Given this list of marker genes Or6x1, Gm3953, Slc35f2, BC049987, Mir34c, Mir6244, Or8g21, Or8ab2-ps1, Arhgap20, Btf3-ps15, Fxyd2, Cd3e, Gm7293, Gm35835, A730065G17Rik, Or8ac1-ps1, Jaml, Gm8863, Olfr932-ps1, Treh, Gm24166, Or8c16, 1700110K17Rik, Bcl9l (NCBI Gene Id 80288), Zbtb16, Hyou1, Or8b1c, Clmp, Or8g52, Or10d5, Nectin1 (NCBI Gene Id 58236), Gm26249, Gm17540, Gm16322, Abcg4, Cbl, Mcam, 2900052N01Rik, Sdhd, Or10n1, Or8b1b, Atm, Or8c20, AI593442, Or10d1, Gm6981, Htr3b, 2610028D06Rik, Il18, Gm25562, 9430081H08Rik, Or8g50, Or8b57 (NCBI Gene Id 258824), Or8b43, Rnf26, 4931429L15Rik, Cyp19a1, Upk2, Or8g30, Or8b54, Gm16096, Scn3b, Apoa1, Or8g25-ps1, Gldn, Or8g26, Gm35371, Gm23271, Nkapd1, Gm5055, Gm9830, Or8b41, Gm48293, Gm24646, Atp5mg, Gm19709, Or8g27, Acat1, Oaf, Pou2f3, Apoc3, Cfap68, Ift46, Zpr1, Mir7086, Arhgef12, Or8g31-ps1, Tnfaip8l3, Ccdc153, Slc37a4, 4833428L15Rik, Exph5 (NCBI Gene Id 330943), Cul5, Gm4042, Plet1os, Lncbate3, Or8g53, Gm31614, Or8c9, Or8d4, Vps11, Gm40518, Usp28, Gm29909, 4933407I05Rik, Btg4, Or8d22-ps1, Or8b1, D630033O11Rik, Nnmt, Cxcr5, Gm39329, Or8g54 (olfactory receptor family 8 subfamily G member 54), Tbcel, Or8g2b, Mir7085, Or8g18, E230034D01Rik, Or8c15, Gldnos, Or8d1b, Skic8, Or8b55, Or8b48, Tmem25, Or8g17, Or8c14-ps1, Pou2af3, Gm4894, Gm1715, Or8c17, 1700063D05Rik, Dixdc1, Gramd1b, Gm7286, Gm47475, Hspa8, Gm16124, Or8g28, Or10s1, Gm22540, Gm10684, Poglut3, Or8g4 (olfactory receptor family 8 subfamily G member 4), Sc5d (sterol-C5-desaturase), Gm5616, Arhgap20os, Mir7087, Kmt2a, Apoa4, Gm31557, Dpagt1, Jhy, Gm36855, Or8g20, Smim35, Tmprss5, Scn2b, Ddx10, Tlcd5, Tmprss4, Or10d4, Gm5364, Gm22659, Or10g9b, Gm39326, Gm39325, Gm8907, Or8g55, Hoatz, Or10d5b, Olfr908, Or10d4b, Or8ab1-ps1, Gm8959, Gm6885, Gm31374, Gm10080, Timm8b, Or8g34, Or8b49, Scn4b, Tagln, Or8g36, Tmprss13, Hspb2, Gm30015, Mir100, Or8b56, Gm40513, Idh3a, Gm35177, Gm16380, Or10g9, Or8c13, Or8b3b, Gm30671, Hinfp, Gm35657, Gm20953, Apoa5, Gm18892, Ankk1, Or10g7, Gm6980, Or8g35, Dmxl2, Pih1d2, Elmod1, Rab39, Or8c10, Sik3, Or10aq1-ps1, Bsx, Vwa5a, Or8c18, Mpzl3, Ube4a, Or8ad1-ps1, Crabp1, E030022I16Rik, Gm32742, Nxpe2, Ubash3b, Gm39336, Or8b1d, Sidt2, Cenatac, Or8d23, Gm10687, Nxpe1-ps, Or8d2, Gm11149, Gm31816 (NCBI Gene Id 102634165), Or8b47, Or8c11, Gm39323 (NCBI Gene Id 102632241), Plet1, Or10n7-ps1, Or8g37, Or8b50, Gm10688, Mirlet7a-2, Gm48277, Or8d2b, Or8ae1-ps1 (olfactory receptor family 8 subfamily AE member 1, pseudogene 1), Gm7368, Gm47629, Mir5710, 1700042D02Rik, 4930510E17Rik, 4930546K05Rik, Or8b51, Gm36435, Or8g23, Mpzl2, Or8g38-ps1, Gm5010, Cadm1, Mir130c, Gm10680, Or8d1, Pcsk7, Or8g24, Gm24278 (predicted gene, 24278), Gm25633, Pou2af2, Pafah1b2, Gm8707, Layn, Gm8543, Gm25558, Gm18586, Or8g2, Foxr1, Ttc12, C2cd2l, 2310030G06Rik, Gm16214, Zw10, Thy1, Trim29, Or10d1c, Sln, AW551984, Tecta, Ncam1, Mfrp, Rpl10-ps3 (NCBI Gene Id 100043346), Dlat, Tex12, Phldb1, Or8b52, Or10n8-ps1, Rnf214, C030014I23Rik, Or8g33, Cryab, Gm57856, Or8c19-ps1 (NCBI Gene Id 258473), Drd2, 5830462O15Rik, Gm26306, Gm17798, Bace1, Or8g29-ps1, Ttc36, Gm31432, 4930448E22Rik, Htr3a, Or8ab1a-ps1 (NCBI Gene Id 404448), Or8g19, Gm19121, Cd3g, A830035O19Rik, Or8c8, Or8g32, Or8b44, Bud13, Or10d3, Gm32335, Or10d4c, Gm39327, Sorl1, Gm22304, Sh2d7 (SH2 domain containing 7), Dnaja4, Alg9, Grik4, 4930550C14Rik, Trappc4, Acsbg1, Nxpe4, Gm36799, Bco2, Or10d1b, Crtam, Zc3h12c, Or8b42, Or10d5j, Rpl26-ps6, Ppp2r1b, Gm21041 (predicted gene, 21041), 2310003N18Rik, Il10ra, Or10m1-ps1, Rps6-ps3 (NCBI Gene Id 672192), Cib2, Rbm7, H2ax, Dscaml1, Or8d6, C1qtnf5, Gm48284, Or8g51, Ddx6, Tmem225, Rdx, Fxyd6, Cldn25, Nlrx1, Gm30934, Pts, Rab7-ps1, Gm35940, Or8b53, Gm22805, Npat, Sik2, Cep164, Or8n1-ps1, Gm5831, Arcn1, Nherf4, Or10o1-ps1 (NCBI Gene Id 404444), Rexo2, Or4d5 (NCBI Gene Id 258601), Usp2, Gm31698, Or10g6, Pou2af1, Cd3d, Gm4791, Mir34b, Gm25401, Mir125b-1, Zfp202, Or8b46, Gm33125, Gm23326, Hmbs, Fdxacb1, Or8g22, Fdx1, Rps25, Or8b3, Gm39321, Gm5617, Mir100hg, Olfr928-ps1, here is a description of the gene set: Mouse Gene Set: chr9A5 studied in species Mus musculus